The following is a description of a gene set: studied in species Homo sapiens Any process involved in the maintenance of an internal steady state at the level of the cell. Human Gene Set: GOBP_CELLULAR_HOMEOSTASIS, and this is the list of marker genes: CALM3, SLC35G1, TBXAS1, CEMIP, SELENOS, B2M, MICU2, VPS33A, DRD1, XCR1, DGAT2, NCF1, SLC1A1, KCNE3, ATP7A, CA7, AIM2, TMEM94, ATP6V0E2, KRIT1, TMBIM6, SCARA5, IREB2, UBE2C, PDPK1, NKX6-1, MYH7B, P2RY1, ELANE, ERN1, SLC8B1, THADA, MCL1, SLC4A1, MUC17, VAPB (VAMP associated protein B and C), WNK4, TMEM199, BLOC1S6, ATP1A3, ASPH, CHRNA1, NPTN, TRPC7, NUCKS1, PAX2, ADCY8, BDKRB1, TRPM4, STIM1 (stromal interaction molecule 1), SLC4A10, NOS3, PDE4D, GSTP1, SYPL2, CASQ1, ANO6, SMARCA4, SLC1A3, SLC39A12, JPH2, NPTX1, RAP1GDS1, ABCC6, TFR2, GLRX3, CALR, SNX10, COX11, DMXL1 (NCBI Gene Id 1657), TMC6, ATP6V1G3, P2RY2, CLN3, NOS1, TYRO3 (NCBI Gene Id 7301), NOX4, GRM5, XCL1, PACS2, STXBP3, LCN6, MIR320D2, MICU3 (mitochondrial calcium uptake family member 3), SNAPIN, ACO1, TMEM38A, DRD3, HAMP, DRD2, LETM1, TXNDC2, CASQ2, GNB3, CACNA1S (NCBI Gene Id 779), PINK1, SLC2A2, STEAP2, GHRL, NELL2, SLC26A6, ABCB8, MT1F, ABCC8, CCL5, ATP6V0A1, RHAG, CHD7, TAOK1 (TAO kinase 1), SLC4A9, LAMP1, CAMK2D, BOLA3, TRPM7, SLC41A1, PLN, ERFE, MIRLET7G, MT4, CNGB1, MT2A, GCG, SLC10A7, PLCL1, LYN, HK1, PSEN1, NOL3, SPNS1 (NCBI Gene Id 83985), HPX, BRSK2, ATP13A3, ATP12A, FTMT, ORMDL1, RPTOR, ABCA2, PRDX1, ATP13A1 (ATPase 13A1), ATP6V0D1, ZBTB20, CLNS1A, BNIP3, ATP6AP1, PPT1, CCDC115, SLC39A4, MCOLN1, MT1A, RAB38, MCUR1, SLC9A8, FXN, SLC39A9, IL1A, CLCC1, ATP13A2, ANK2, CCL7, HK3, GRN, ATP6V1C1, GLS, MLXIPL, CYBRD1, ATP1B3, UBTF (upstream binding transcription factor), RYR1, ATOX1, CRH, CLCN6, PTPRN, CARTPT, SLC39A7, METTL21C, NCOA4, AVPR1A, DMD, PPP3CB, E2F4, MT1M, SLC22A12, TMEM106B, SELENOK, CLN5, LGSN, RHCG, IGF1, FZD9, HCRTR1, SLC24A2 (solute carrier family 24 member 2), FOXA2, BAIAP3, SLC22A17, HAAO, FSHR, PRDX2, MT1X, NGF, CORO1A, SV2A, MIR320C2 (microRNA 320c-2), SMAD9, COL1A1, MIR133A1, FBXW7, CCR1, WNK3, BMP6, TASL (TLR adaptor interacting with endolysosomal SLC15A4), RNF135, ALAS2, UCP2, SELENOT, GPER1, FUT1, RAB39A, MAP1A (NCBI Gene Id 4132), XPR1, BCL2, BAG3, ADRA2A (NCBI Gene Id 92480), SLC12A3, RHOT1, ATP1A2, NUBP1, HKDC1, CD19, ATP6V1B1, STOML2, CALM2, SLC26A3, ATP4A, TMEM178A, SLC8A1, PRDX5, PLCB4, ABCA12, BOK, FTH1P19, PLCH2, SLC39A10, MT3, KEL, ATP2C1, CCDC186, IL6, CCDC22, PTH, GPR89B, LCK, FRRS1, ATP1A4, MIR320A, NR1H4, MCU, PCK2, LACRT, NDUFAF2 (NADH:ubiquinone oxidoreductase complex assembly factor 2), TMPRSS6, HEXB, C1QTNF12, C19orf12, CCL8, HMOX1, CCL23, ATP6V1E1, MT1E, KCNN4, AGER, SCNN1A, MCUB, PTPRN2, SLC39A14, GSTO1, SNCA, CACNB4, SLC4A2, CAPN3, MSTN, ATP2B4, SLC4A3, GLUL (glutamate-ammonia ligase), OCA2, STC1, GIT1, MIR16-1, SRF, TMEM165 (NCBI Gene Id 55858), ATP2A1, GLRX5, TRPM5, GRID2IP, VDR, COX19, CCL2, MIR337, CCL11, TRPA1, SLC9A9, TRPM8, CAV3, PRDX4, IBTK, FTL, SLC2A10, SLC25A27, TRPC5, UNC13B, RAB11FIP5, ATP6V1A, PIK3R1, TNS2, STEAP4, PIK3CB, FTHL17, FBXO4, SLC9A1, PICALM, SMAD4, NR1D1, SLC7A11, HTT, SLC34A3, TRIM32, SLC25A23, HIF1A, CALCB, PLCB1, SCNN1D, SERPINF1, WNK1, PLCG1, NQO1, FBXL5, SLC34A2, SLC39A6, ATP1B2, CXCL10, HTR2B, ATP6V0B, SLC31A2, LARGE1, BAD, MT1DP, ADORA1, VSNL1, ATP4B, ATP1A1, ERC2, FOXO1, APLNR, WBP2NL, CACNB2, SMARCB1, TMEM203, CDK16, CXCR3, WDTC1, P2RX7, ATP1B1, SCTR, TXN2, FXYD2, TPP2, SCO2, ATG5, ANKH (ANKH inorganic pyrophosphate transport regulator), TPT1, TSC22D4, GPRC5B, HTR2A, NPM1, CFTR, MAPK1, LETMD1, GDF2, KCTD17, KCNJ2, SELENON, AKAP6, SLC4A8, STC2, SLC24A3, FOXO3, GPR12, MIR1-1, LCN2, CHMP2B, ARF1, ANO1, STIM2, NEO1, MAIP1, WFS1, SLC24A5, SCN7A, STK39, AFG3L2, EDN3 (endothelin 3), EGLN2, THY1, OPRK1, ATP6V1G1, TXNRD1, GCK, DIAPH1, ALDOA, SLC39A5, SLC4A4, SLC11A2, SLC9B2, TMEM9, ATP13A5, TRPC6, OXCT1, FGGY, TRPV4, CAV2, IL2RG, SMAD3, ANKRD9, SLC29A1 (NCBI Gene Id 220811), ADCY5, AVP, PIH1D1, MTLN, PTPRC, HERPUD1, C1QTNF3, WNT5A, RBM4, SLAMF8, NPPC, SLC30A10, UBE2K, ATP6V1H, CLCN3 (chloride voltage-gated channel 3), BOLA2, JAGN1, SLC9A6, CCL19, TSPOAP1, IGF1R, MT1B, TXN, TPCN2, ENPP1, CISD1, IL13, AQP4, APOE, GP5, RAC1, ENDOG, BOLA2B, GCKR, LIN28A, DYNLL1, CP, TNNI3, MPC2, DEDD2, SMDT1, ATP2A3, PRKAA2, CDH5, TFRC, SLC40A1, SMAD5, ERO1A, TM9SF4, SLC30A7, FOXK1, ATP6V1F, PLCE1, NPY, ZBED6, FLVCR1, TRIM6, SLC9C2, HJV, HFE, ELP6, SLC12A2, PML, AP3B1, HEPHL1, CHRNA7, GPRC6A, KAT5, ABCB6, SLC30A9, SLC9A2, SLC12A1, F2, GHRHR, SLC9C1, MIR146A, TMEM175, ZNF236, C2CD2L, CXCL12, SLC4A5, PLG, TRPC1, GCLC, MINPP1, YWHAE, PKD2, NFE2L1, KCNK16, CREG1, CNR1, PLCH1, LRRC8E, FUNDC2, FASLG, DISC1, JPH1, RAB11B, ABL1 (ABL proto-oncogene 1, non-receptor tyrosine kinase), LACC1, NADK, HVCN1, LRRK2, MT1G, SOD2, LRRC8D, IFNB1, OSBP, ACACB, KLF15 (KLF transcription factor 15), CALB1, NFE2L2, STXBP4, LRRC8A, SMAD1, LIME1, SLC30A8, ATF4 (activating transcription factor 4), FLNA, PIM3, TGFB1, OSBPL2, MIR320B1, DHRS7C, CCL3, SLC30A1, CCR2, DRD5, GPLD1, CROCC, BAX, CMA1, LOX, SLC12A8, SLC9A5, MIR15A, MYC, XBP1, GP1BA, ATP13A4, SLC12A9, IFNG, MAPK3, RGN, FKBP1B, IRS2, AQP11, PRKN, OGT, UMOD, P2RX1 (NCBI Gene Id 5023), CXCL11, GHITM, TMTC4, GP1BB (glycoprotein Ib platelet subunit beta), OXSR1, RYR2, HSP90B1, PRKCE, USF2, MIR320E, ITPR2, SOD1, BAP1, KCNQ1, F2RL3, FGF2, GPR68, GCM2, WNT7B, LARGE2, ACVR2B, MIR320C1, DMTN, EDN1, ATP2B1, MTM1, SLC8A2, CXCL9, SLC45A2, ITPR3, GJB6, MT1H, ATP6V0E1, CASR, BOLA1, GRM2, PCK1, ADNP, KCTD7, RYR3, XK, PLCG2, SLC38A3, ANXA6, AMBRA1, CAV1, SCO1, TRPM2, GSTM2, GATA4, CA2, GRM1, PPARGC1A, SLC30A2, DCTN1, SLC31A1, PRNP (NCBI Gene Id 96713), PLCL2, ERO1B, P2RY6, RHOT2, ATP6V0A2, TMCO1, SPPL2C, CLIC4, HK2, CLTRN, JPH3 (junctophilin 3), PPARD (NCBI Gene Id 5467), CHERP, IDE, NDFIP1, TMEM38B, TTC7A, CYBA, PLAA, FOXA3, SLC12A6, GPR89A, PRDX6, PNPLA2, SV2B, TRDN (NCBI Gene Id 10345), NPSR1, PDE8B, FIS1, MT1HL1, TUNAR, PRKAA1, ATP6V0A4, MIR93, PTH1R, CCR5, PTPN6, EGLN1, RFX6, ATP2C2, GRINA, PKHD1, SHANK3, ATP6V0C, GPX1, UBE2S, TXNRD2, SLC30A5 (solute carrier family 30 member 5), GRIK2, FKBP1A, SYBU, IL7R, ATP6V1D, BAK1, SIDT2, PHPT1, TRA2B (NCBI Gene Id 6434), RNASEK, CHP1, TRPC3, PIK3R2, UBE3A, SLC9A3, USF1, ATP2B3, HAP1, JPH4, CLN6 (CLN6 transmembrane ER protein), SLC17A7, CALB2, TXNRD3 (NCBI Gene Id 93415), ORMDL2 (ORMDL sphingolipid biosynthesis regulator 2), ATP6AP2, SLC6A2, CYP7A1, PRND, CFL2, RAF1, TESMIN, ITPR1, SCT, IMMT, ASL, RMDN3, CYB561A3, ATP2B2, FOXK2, SLC12A7, CD40, SLC46A1 (NCBI Gene Id 113235), SRI, MICU1, CNNM4, HCRTR2, SLC12A5, CLIC2, PFKM, KCNMA1, ATP7B, NHERF1, TCIRG1, AQP1, KLF7, SLC12A4, CACNA1C, SLC39A13, NNT, RACK1, SLC24A1, SLC4A11, GPR27, SIN3A, ICAM1, CTRC, NGFR, MIR320B2, EPHA5, TGM2, VPS54, CYB561, FGF23, CHD6, PDX1 (NCBI Gene Id 3651), DMXL2 (NCBI Gene Id 23312), GP9, PTK2B, CALCA, APEX1, ITGB3, CIAO3, SLC39A8, ERP44, CCR7, F2R, SLC11A1, SCNN1G, STX4, DMPK, PLCB2, SLC66A1, HTR2C (NCBI Gene Id 3358), MIR103A1, GCLM, GSR, CCL14, TREM2, RAB11FIP2, PLA2G6, GAA (alpha glucosidase), CSRP3, TF, SGCZ (NCBI Gene Id 137868), SLC4A7, KCNB1, SLC9B1, ATP6V0D2, SLC8A3, SLC9A7, ABCB7, SCNN1B, PDZD8, NTSR1, GLRX2, CCDC51, EFNA5 (NCBI Gene Id 1946), SOX4, TMEM64, RTN4, RAB7A, CDH23, SLC24A4, TRPC4, ATP6V1G2, PRKCB, ISCU, MIR210, CCL1, ORMDL3, PRKD1, SIRT1, CCL21, LRP5, EDN2, GAS6, CCDC47, CCL13, DRD4, DDIT3, EDNRA, ATP6V1B2, MECR, CALM1 (calmodulin 1), FITM2, APP, PLCB3, UBASH3B, ATP5F1B, PRDX3, LDAH, SLC34A1, CLDN16, LAMP2, DNAJB2 (NCBI Gene Id 3300), CX3CL1, PIK3CA, NOS2, TMC8, ALPL, TMPRSS3, RAB20, ATP2A2, HLA-DRB1, HRC, MIR320D1, FATE1, SLC9A4, CCL15, PRKACA, FTH1, ENY2